Given this list of marker genes ABCB11, ABCC11 (NCBI Gene Id 85320), SLC36A1, ABCC4, ABCC3, here is a description of the gene set: Enables the transfer of an organic acid from one side of a membrane to the other according to the reaction: ATP + H2O + organic acid(out/in) = ADP + phosphate + organic acid(in/out). species: Homo sapiens Human Gene Set: GOMF_ATPASE_COUPLED_ORGANIC_ACID_TRANSMEMBRANE_TRANSPORTER_ACTIVITY